Given this list of marker genes FXYD2, CLDN16 (claudin 16), ATP1A1, CLDN19, IFT122, KCNJ10, SLC12A3, here is a description of the gene set: species: Homo sapiens High urine magnesium in the presence of hypomagnesemia. Human Gene Set: HP_RENAL_MAGNESIUM_WASTING Renal magnesium wasting